Given this list of marker genes FOXP3 (NCBI Gene Id 50943), TFAP2B, CYP2S1, KLF7, PPP1R7, URGCP, ZSWIM6, OPCML, CDKL1, NF1, SPAG8, ARL8B, PJA2, NR3C1, PSEN1, GRIK2, SHB, EEA1, GPRC5B, SPRED2, ZNF697, NRBF2, TSPAN7, TLX1, NFAT5, PXDNL, FABP2, BMP4, PITX2, RTN4, KIAA1549L, PDP1, DYNLL1, CHMP7, TUBGCP4, PARP12, BCAP29, CTBP1, FAM131A, PRPS2, GRID1, RNF41, PURA, DAB2, KCNIP4, CCDC92, RNF130, CX3CR1, PODN, PTPRR, CHP1, WDR44, CREBRF, NLGN4X, TMEM123, PAX3, CDK6, VIPAS39 (NCBI Gene Id 63894), FXYD3, SCN2A, SMARCC1, B3GNT9, DNASE1L1, here is a description of the gene set: studied in species Homo sapiens Genes predicted to be targets of miRBase v22 microRNA hsa-miR-644a in miRDB v6.0 with MirTarget v4 prediction scores > 80 (high confidence targets). from publication Chen Y, Wang X (PMID 31504780) Human Gene Set: MIR644A